The following is a description of a gene set: Human Gene Set: HP_URINARY_BLADDER_SPHINCTER_DYSFUNCTION studied in species Homo sapiens Urinary bladder sphincter dysfunction Abnormal function of a sphincter of the urinary bladder., and this is the list of marker genes: FXN, GFAP, WWOX, GBE1 (1,4-alpha-glucan branching enzyme 1), SPG7, GJC2, ZFYVE26, ABCD1, SPAST, MMP1, NIPA1, SETX, ATXN1, COL7A1, HNRNPA2B1, FMR1, MPZ, ATXN3, KIF1A, AP5Z1, HNRNPA1, WASHC5, RTN2, PIK3R5, VCP, HSPD1, KIF5A, ATL1, ATXN2, REEP2, PMP22, SPG11